The following is a description of a gene set: Human Gene Set: GOMF_MOLECULAR_SEQUESTERING_ACTIVITY species: Homo sapiens Binding to a specific molecule to prevent it from interacting with other partners or to inhibit its localization to the area of the cell or complex where it is active., and this is the list of marker genes: CALR, SDCBP, KIFBP, DDX56, MT3, TSSC4, WDR44, CD69, EPN1, SMAD6, TREM1, YWHAG, YWHAE (NCBI Gene Id 7531), SLC39A4, GOPC, ERFE, TCN1, SQSTM1, YWHAB, NORAD, NFKB1, TARBP2, SEC14L1, IMPACT, CTNND1, SESN2, SRI, SFN, LRRC15 (NCBI Gene Id 131578), MYT1L, C1R, XAF1, SPI1, CASTOR1, IFIT1, PMEPA1, INSIG1, YWHAZ, USP9X (NCBI Gene Id 8239), INSIG2, FTH1 (NCBI Gene Id 92182), ZAR1, NCK1, NFKBIA, CDKN1A, DBN1, PRDX4, NFKBIE, TRIM15, NOSIP, FLNA, HSPBP1, LCN2, TMSB4X, STAT3, LAPTM5, S100A7, SMO, MDFI, CASQ2, TTR, CAV1, RBCK1, TMC8